Given this list of marker genes SIX4, LIN7B, LIN7C, LIN7A, SLC18A3, SIX1, AGRN, PDZD11, COLQ, DCTN1, MUSK (NCBI Gene Id 4593), MYCBP2, here is a description of the gene set: Human Gene Set: GOBP_REGULATION_OF_NEUROMUSCULAR_JUNCTION_DEVELOPMENT Any process that modulates the frequency, rate or extent of neuromuscular junction development. studied in species Homo sapiens